Given this list of marker genes CTF1, LRRC28, COL1A2, CPB1, ZBTB20, RHOB, LAMP5, TRAV27, HBA1, INS, PRSS3, COL1A1, ENPP1, PARP6, CTRB2, PRSS2, KIAA1217 (KIAA1217), COL3A1, H19, SOX9, RET, CELA3B, CELA3A, APOE, GPIHBP1, POSTN, CELA2B, SEMA4C, here is a description of the gene set: To determine the influence of the microenvironment on changes in gene expression, we did microarray analysis on three variant lines of a human pancreatic cancer (FG, L3.3, and L3.6pl) with different metastatic potentials. The variant lines were grown in tissue culture in the subcutis (ectopic) or pancreas (orthotopic) of nude mice. Compared with tissue culture, the number of genes of which the expression was affected by the microenvironment was up-regulated in tumors growing in the subcutis and pancreas. In addition, highly metastatic L3.6pl cells growing in the pancreas expressed significantly higher levels of genes than did the L3.3 or FG variant cells. Growth of the variant lines in the subcutis did not yield similar results, indicating that the orthotopic microenvironment significantly influences gene expression in pancreatic cancer cells. These data suggest that investigations of the functional consequence of gene expression require accounting for experimental growth conditions. studied in species Homo sapiens Human Gene Set: NAKAMURA_CANCER_MICROENVIRONMENT_UP Genes up-regulated in pancreatic cancer cells grown in orthotopic xenograft tumors compared to those grown in vitro. from publication Nakamura T, Fidler IJ, Coombes KR (PMID 17210693)